Given this list of marker genes Slc6a4, Pde3a, Hcn4, Npr2, Hcn2, Pde2a, Rapgef2, here is a description of the gene set: Any process that results in a change in state or activity of a cell (in terms of movement, secretion, enzyme production, gene expression, etc.) as a result of a cGMP (cyclic GMP, guanosine 3',5'-cyclophosphate) stimulus. Mouse Gene Set: GOBP_CELLULAR_RESPONSE_TO_CGMP studied in species Mus musculus